Given this list of marker genes PAFAH1B1, HS3ST2, ZNF335 (zinc finger protein 335), MBNL2, TRAF4, ZIM2, RIPOR1, HS3ST3A1, ASPHD1, SEMA4C, PACRGL, UCN, CTC1, RALGAPA1P1, RNF7, RUNDC3A (RUN domain containing 3A), AREG, SDHB, ZFAND2B, BRAF, AVPI1, ELOVL5, IFT20, ZBTB11, LTBP1, CYSTM1, SCG2, BABAM2, RAD51C, YWHAZ, MLF2, NDUFB2, MMGT1, GEM, DDX19A, SIK1, TNFAIP1, MYL6, PNMA3, CDS1, RNF44, BNIP3L, LMCD1, MRM3, YTHDC2, IRF2BPL, ZFYVE27, WFDC3, TSC22D2, DDX28, RBP5, TMEM39A, PNMA6A, ATP6V0C, GPM6B, NUP214 (NCBI Gene Id 9680), SUV39H2, PFAS, ZBTB37, ZC3H10, PHACTR3, NR2E1, HDX, PPP1R15A, FAM174A, PDLIM3, AFF4, CAMK2D, DUS2, PTPRU, ING4, DEPDC4, RELB, OSBPL9, SLC18A2, ADCY8, VGF, EPHA2, GTF3C1, SST, TAOK2, RBKS, ADNP2, TMEM59L, SYNGR3, GPR3, MAPK10, MRGPRF, MAFF, ZNF593, OGDH, G3BP2, EPB41, KICS2, GLI1, DNAJC27, KCNA5, CLDN6, CDX4, PCSK1, CCNA2, PLCD3, CYLD, SPAG9, INTS7, WNT10A, TRAP1, ALS2, RAI1, SLC38A1, GNB4, TEX14, TIPRL, ATG5, CXCL16, PNRC1, NUP98, THADA, ZNF516-DT, AKIRIN1, PARD6A (par-6 family cell polarity regulator alpha), C11orf87, TMEM147, CENPE, SPATA7 (NCBI Gene Id 55812), ID1, DNTTIP1, MAOA (monoamine oxidase A), STAT3, ZNF576, ABHD16A, CLDN7, GNL1, DHX36, NR4A2, RUSC1-AS1, JUND, MRRF, PDP1, UMPS (NCBI Gene Id 7372), CRH, FOXD3, FGF6, FLT1, ATL2, NOC4L, ELL2, NDUFA10, NF1, KYAT1, HSP90AB1, CHPF, DUSP1, NOL4, GPBP1, CCDC148, PPM1A, H4C5, KCNF1, CLSTN3, CMSS1, TSPAN7, ANAPC10, UBE2H, MAP3K13, GLOD4, LGR5, MAP1LC3A, EEF2, THOC1, TP53INP2, TGIF2, TBC1D32, ZMYM2, SCAMP5, RCE1, SNAP25, MITF, SGIP1, RPRD1A, PPP2R2A, DDX51, PPARGC1A, ABCE1, TH, VPS37B, OSR1, ZMYND15, IRX6, CREM, RBM18, C1orf35, ST13, PER1, FAM131A, CD2AP, PITX2, XPNPEP3 (X-prolyl aminopeptidase 3), CCN4, SRRM4, CHGB, DCTN1, CHMP1B, HAS1, MAF, PRR3 (proline rich 3), LDHA, NUP42, AHI1, ZNF367, USP48, ARL4D, NCALD, ADAP1, ARIH1, RCAN1, SULT4A1, NUBPL, NEUROD6, SENP2, DIO2, MCAM, CBX8, IKBKB, IRX4, PKP4, RAB25, RUSC1 (RUN and SH3 domain containing 1), ZNF184, DAAM2, KCTD8, RPS29, RPL41, SLC25A25, PEG3, here is a description of the gene set: from publication Xie X, Lu J, Kulbokas EJ, Golub TR, Mootha V, Lindblad-Toh K, Lander ES, Kellis M (PMID 15735639) Genes having at least one occurrence of the highly conserved motif M14 TGACGTCA in the regions spanning 4 kb centered on their transcription starting sites. This matches the ATF3 transcription factor binding site V$ATF3_Q6 (v7.4 TRANSFAC). Comprehensive identification of all functional elements encoded in the human genome is a fundamental need in biomedical research. Here, we present a comparative analysis of the human, mouse, rat and dog genomes to create a systematic catalogue of common regulatory motifs in promoters and 3' untranslated regions (3' UTRs). The promoter analysis yields 174 candidate motifs, including most previously known transcription-factor binding sites and 105 new motifs. The 3'-UTR analysis yields 106 motifs likely to be involved in post-transcriptional regulation. Nearly one-half are associated with microRNAs (miRNAs), leading to the discovery of many new miRNA genes and their likely target genes. Our results suggest that previous estimates of the number of human miRNA genes were low, and that miRNAs regulate at least 20% of human genes. The overall results provide a systematic view of gene regulation in the human, which will be refined as additional mammalian genomes become available. Human Gene Set: TGACGTCA_ATF3_Q6 species: Homo sapiens